Given this list of marker genes Rhoh, Cyba, Picalm, Stard13, Fgd2, Arhgap33, Samm50, Arhgef15, Cdc42, Farp1, Arhgap28, Arhgap19, Ckap4, Arhgef12, Slitrk5, Trip10, Ophn1, Scfd1, Akap12, Ddx4, Bcap31, Wasf3, Ncf2, Arhgap15, Nudc, Gmip, Ankle2, Lbr, Ptpn13, Stam, Vav1, Arhgap12, Steap3, Pak6, Fam13a, Mcam, Aaas, Arhgdig, Wasf1, Arhgef7, Plekhg6, Arhgap42, Cct7, Tagap, Rnd1, Arhgap26, Rtkn, Rhoj, Depdc1b, Dock2, Mpp7, Armcx3, Basp1, Fam169a, Frs2, Kidins220, Vangl1, Csk, Pak3, Arhgap40, Racgap1, Arhgap45 (NCBI Gene Id 70719), Muc13, Hmox2, Sema4f, Faf2, Baiap2l1, Vcp, Dock5, Emd, Arhgap9 (Rho GTPase activating protein 9), Slitrk3, Pak4, Arhgap10, Itsn1, Emc3, Arhgap11a, Cav1, Plxnd1, Dock8, Rbmx, Arhgef10, Dnmbp, Tor1aip1, Jup, Cct6a, Mtmr1, Swap70, Fgd1, Fam83b, Tnfaip1, Acbd5, Diaph2, Arhgef3, Atp6ap1, Tpm3, Ckb, Flot2, Fmnl2, Epha2, Wwp2, Arhgap25 (Rho GTPase activating protein 25), Rhob, Cct2, Lck, Ubxn11, Rac2, Ccdc187, Letm1, Cyfip2, Esyt1, Arhgdib, Baiap2l2, Twf1, Rhov, Gopc, Tmem87a, Ndufs3, Pik3r2, Ocrl, Stk10, Arap1, Rnd2, Wdr6, Noxo1, Gfod1, Dsg1a, Prex1 (NCBI Gene Id 277360), Vim, Pld2, Rhou, Actc1, Vangl2, Ndufa5, Lmnb1, Rab7, Uaca (NCBI Gene Id 72565), Plekhg3, Zfp512b, Lrrc1, Arhgap18, Fermt2, Dlc1, Pcdh7, Sos2, Ncf1, Arhgef10l, Stard8, Rhpn1, Hspe1, Pde5a, Arhgap22, Fgd5, Nsfl1c, Arhgef39, Gna13, Fam13b, Dock11, Cpd, Pgrmc2, Rac3, Txnl1, Arhgap44, Gja1, Vrk2, Ccdc115, Noxa1, Arhgap17 (NCBI Gene Id 70497), Spen, Grb2, Ktn1, Cdc37, Sh3bp1, Arhgef17, Arhgap8, Nox3, Lamtor1, Pkn1, Msi2, Flot1, Tuba1b, Arhgef1, Tmod3 (tropomodulin 3), Ngef, Lman1, here is a description of the gene set: part of: Signaling by Rho GTPases studied in species Mus musculus Reactome Pathway: RHO GTPase cycle electronically inferred by orthology from the curated human pathway This event has been computationally inferred from an event that has been demonstrated in another species.<p>The inference is based on the homology mapping from PANTHER. Briefly, reactions for which all involved PhysicalEntities (in input, output and catalyst) have a mapped orthologue/paralogue (for complexes at least 75% of components must have a mapping) are inferred to the other species.